The following is a description of a gene set: Perineal fistula species: Homo sapiens Human Gene Set: HP_PERINEAL_FISTULA The presence of a fistula between the bowel and the perineum., and this is the list of marker genes: NCF4, CD3G, KDM6A, TCTN3, PKP1, ELF4, KMT2D, SALL1, CDK8 (cyclin dependent kinase 8), TGFB1, RECQL4, SYK, DACT1, HPS6